Given this list of marker genes CDR2L, ABHD5, MZF1, LRRC4, KRBOX5, CNEP1R1, GSE1, RGPD1, STAU1, NFAT5, NBEA, ZSCAN22, ZFAND5 (NCBI Gene Id 7763), ZNF268, ARK2C, AKR1B15, ZNF594 (NCBI Gene Id 84622), KPNA5, ZNF584, TMEM101, EID1, VPS35, CHRNA4, FNDC3A, MAFA (NCBI Gene Id 389692), KLHL12, ZNF135, HOXA9, EBF1, YPEL5, TXNRD3, GCNT2, ADNP2, SPATA33, KPNA4 (karyopherin subunit alpha 4), GPR19, ZMYND11, DLG2, TAPT1, TGOLN2, ZNF773 (NCBI Gene Id 374928), CYB561D1, METTL8, ZNF711, ZNF74, ZEB2, here is a description of the gene set: Genes predicted to be targets of miRBase v22 microRNA hsa-miR-548q in miRDB v6.0 with MirTarget v4 prediction scores > 80 (high confidence targets). from publication Chen Y, Wang X (PMID 31504780) studied in species Homo sapiens Human Gene Set: MIR548Q